Given this list of marker genes SLC8A2, SLC8A3 (solute carrier family 8 member A3), ATP2B4, P2RX2, ATP2A1, ATP2B2, P2RX4, ITPR2, TRPC3, TRPC6, ATP2B3, P2RX3, ITPR3, SRI, P2RX1, ATP2B1, ORAI2, ITPR1, ATP2A3, STIM1, P2RX6, SLC8A1, ORAI1, ATP2A2, CALM1, P2RX7, P2RX5, TRPC7, here is a description of the gene set: Ca2+ homeostasis is controlled by processes that elevate or counter the elevation of cytosolic Ca2+. During steady state conditions, cytoplasmic Ca2+ is reduced by the accumulation of Ca2+ in intracellular stores and by Ca2+ extrusion. The primary intracellular calcium store in platelets is the dense tubular system, the equivalent of the ER system in other cell types. Ca2+ is extruded by Ca2+-ATPases including plasma membrane Ca2+ ATPases (PMCAs) and sarco/endoplasmic reticulum Ca2+ -ATPase isoforms (SERCAs). <br><br>Activation of non- excitable cells involves the agonist-induced elevation of cytosolic Ca2+, an essential process for platelet activation. It occurs through Ca2+ release from intracellular stores and Ca2+ entry through the plasma membrane. Ca2+ store release involves phospholipase C (PLC)-mediated production of inositol-1,4,5-trisphosphate (IP3), which in turn stimulates IP3 receptor channels to release Ca2+ from intracellular stores. This is followed by Ca2+ entry into the cell through plasma membrane calcium channels, a process referred to as store-operated calcium entry (SOCE). Stromal interaction molecule 1 (STIM1), a Ca2+ sensor molecule in intracellular stores, and the four transmembrane channel protein Orai1 are the key players in platelet SOCE. Other major Ca2+ entry mechanisms are mediated by the direct receptor-operated calcium (ROC) channel, P2X1 and transient receptor potential channels (TRPCs). studied in species Homo sapiens part of: Platelet homeostasis Reactome Pathway: Platelet calcium homeostasis